Given this list of marker genes TCAF2, CCT3, CEACAM1, NIFK, TBC1D15 (NCBI Gene Id 64786), PUS7, DYRK2, JAK3, SLC7A1, ARID5A, STAMBPL1, HPRT1, CCT2, PNO1, SEH1L, STAT5A, WDR74, IL21R, TAF4B, EPHB4, PIM2, FLOT1, CTSA, TSPAN3, SLC39A14, ZDHHC16 (NCBI Gene Id 84287), ZNF101, PCED1B, ENO1, AHCY, SFXN4, TSEN2, SBNO2, PMS1, C1QBP, SCFD2, DCTD, C3, HDAC2, TFPI2, STAT3, LARP1, TP53, RPIA, NAXE, DHPS, IPO5, MDN1, NDST2, PFKFB3, IKZF1, NME2P1, ZDHHC9, ATIC, LRRC58, SREBF1 (NCBI Gene Id 6720), SULT1B1, LINS1, MTHFD1L, SRM, G3BP1, PAK1IP1, BYSL, REXO2, KAT6A, NOTCH1, RNF157, ID2, NOL10, HSPD1, UBASH3B, NARF, NTAQ1, CMTM8, RUVBL1, HIF1A, POLR1A, SLC7A5, ZNRF1, KDSR, GNL3, DDX10, PUM3, CLUAP1, MRPS25, URB2, TMEM65, SOCS1, RFC2, TFB2M (transcription factor B2, mitochondrial), MRTO4, SP110, RRS1 (ribosome biogenesis regulator 1 homolog), SFXN2 (sideroflexin 2), POLD2, EIF3B, MET, WDR43, NOL6, BCL6, TAF8, NUDCD1, TRMT1, IL1B, RRP12, LPCAT3, PAICS, NOLC1, TACO1, UTP4, CTPS1, INTS10, LRP8, POLR1B, NOP2, UTP20, PGK1, PFAS, MYC, POLR1C, GNL2, APBA2, BAZ1A, F2RL1, GPRIN3, NAA15, PDK1, NFKBIZ, CXCL5, GPATCH4, DTNBP1, CEP112, SFMBT2, NUP205, JUNB, NOP14, RIOK1, PPRC1, HNRNPAB, PIM1, DDX21, XRN2, PHB1, UBE3C, IL2RA, SOCS3, CDK4, SRPRB (NCBI Gene Id 58477), FARSB, CXCL1, PPIL1, ANKRD17, IMPDH2, SNORA6, MAT2A (methionine adenosyltransferase 2A), CISH, ADD2, NAA25, LMNB1, FAM184A, SOD1, GTF3A, WDR12, GTPBP4, SFPQ, EXOSC5, LDHA (NCBI Gene Id 3939), ALDH18A1, CDK2, PRXL2A, MSL3, RPF2, LARS1, NOC3L, CMSS1, ATP2B4, DCTPP1, ITGA6, SIN3A, RAPGEF6, WDR3 (WD repeat domain 3), ITK, KICS2, TSPAN17 (tetraspanin 17), PDIA5, EIF4G1, CAD, PPP1R3B, SORD, HEATR1, TRAP1, ARID5B, HSP90AB1 (NCBI Gene Id 3326), KAT2A, RANBP1, HNRNPR, POLR3D, here is a description of the gene set: Genes down-regulated in CD4 T cells with STAT3 knockout: medium versus IL6. from publication Durant L, Watford WT, Ramos HL, Laurence A, Vahedi G, Wei L, Takahashi H, Sun HW, Kanno Y, Powrie F, O'Shea JJ (PMID 20493732) STAT3, an essential transcription factor with pleiotropic functions, plays critical roles in the pathogenesis of autoimmunity. Despite recent data linking STAT3 with inflammatory bowel disease, exactly how it contributes to chronic intestinal inflammation is not known. Using a T cell transfer model of colitis we found that STAT3 expression in T cells was essential for the induction of both colitis and systemic inflammation. STAT3 was critical in modulating the balance of T helper 17 (Th17) and regulatory T (Treg) cells, as well as in promoting CD4+ T cell proliferation. We used chromatin immunoprecipitation and massive parallel sequencing (ChIP-Seq) to define the genome-wide targets of STAT3 in CD4+ T cells. We found that STAT3 bound to multiple genes involved in Th17 cell differentiation, cell activation, proliferation and survival, regulating both expression and epigenetic modifications. Thus, STAT3 orchestrates multiple critical aspects of T cell function in inflammation and homeostasis. Human Gene Set: GSE21670_UNTREATED_VS_IL6_TREATED_STAT3_KO_CD4_TCELL_DN studied in species Homo sapiens